The following is a description of a gene set: species: Homo sapiens The chemical reactions and pathways resulting in the breakdown of mRNA, messenger RNA, which is responsible for carrying the coded genetic 'message', transcribed from DNA, to sites of protein assembly at the ribosomes. Human Gene Set: GOBP_MRNA_CATABOLIC_PROCESS, and this is the list of marker genes: MAGOH, FXR2, ARID5A, MIR204, MIR133A1, ATM, CNOT8, HNRNPAB, IGF2BP2, FASTKD1 (FAST kinase domains 1), FASTKD5, MIR103B1, MIR519D, A1CF, MIR373, MIR517A, MIR210, DIS3L2, DAZ4, HNRNPA0, NPM1, ZC3H12D, TENT2, FASTKD2, ZFP36L1, MIR106B, MIR4286, MIR192, MIR495, MIR485 (NCBI Gene Id 574436), MIR497, BTG2, MIR663A, DIS3, CNOT11, MIR365A, MAPKAPK2, TNRC6B, CNOT6, MIR27A, MIR206, ZAR1, EIF4ENIF1, RBM46, NUDT16, MIR543, MIR181D, MIR486-1, MIR106A, CNOT2, RBM33, MIR203A, CELF1, DHX34, ETF1, RBM38, MIR181B1, PDE12, ZC3HAV1, MIR30B, SSB, CNOT3, AXIN2, MIR128-1, NCBP1, MIR20B, MAPK14, MIR655, PIWIL2, TNRC6C, IGF2BP1, MIR212, EXOSC7, PABPC4, LSM5, SENP1, MIR200C, CASC3, UPF3A, PABPN1L, TUT7, MIR562, TIRAP, BOLL, GSPT1, MIR98, NUDT12, ZFP36 (NCBI Gene Id 7538), ZFP36L2, TENT5D, RC3H1, ELAVL4, MIR520C, PNRC2, MEX3D, TENT5C, LSM4, GDNF, LSM2, RIDA, AGO4, MTPAP, MIR885, APEX1, FASTKD3, MIR519A1, PIWIL1, SMG8, TESK1, CNOT1, METTL14 (NCBI Gene Id 57721), MIR665, PYM1, AGO2, NT5C3B, ELAVL1, NBDY, HSPA1B, MIR181A2, CTIF, DHX9, TNRC6A, MIR24-1, TENT5A (terminal nucleotidyltransferase 5A), SKIC2, TENT5B, MIR93, NORAD, UPF1, IKBKE, PKP1, EXOSC5, MIR608, PRR5L, MIR151A, CSDE1, MLH1, MIR423, MIR100, MIR125A, PNRC1, YBX3 (Y-box binding protein 3), MIR142, EDC4, TAF15, TTC5, MIR342, MIR27B, MIR190B, MIR544A, RNPS1, PUM1, MAGOHB, PAN2, GTPBP1, ALKBH5, MIR140, MIR34B, HBS1L, GSPT2, RC3H2, ZC3H14, CIRBP, SKIC3, CACNG7, MIR191, PARN, APOBEC1, MIR337, CSDC2, TRAF2, QKI, NRDE2, ROCK1, EXOSC4, MIR340 (microRNA 340), EXOSC2, NANOS3, MIR149, UPF2, RBM24, PAN3, MIR1-1, NICOL1, AGO1, DXO, MIR199B, POLR2G, SERBP1, SMG9, MIRLET7C, TNKS1BP1, CNOT6L, MIR29B1, NCBP2, KHSRP, NANOS2, MIR137, PRKCD, CNOT4, SMG5 (SMG5 nonsense mediated mRNA decay factor), SUPV3L1, CALCR, PELO, EXOSC3, ZHX2, MIR424, PAIP1, LARP4B, NBAS, MIR329-1, LSM14B, ZC3H12A, MIR320A, ERN1, VIP, TUT1, TENT4A, DAZ3, HSPA1A, YBX1, EXOSC10 (NCBI Gene Id 8619), PABPC1, RBM10, MIR125B1, FBLL1, CNOT10, MIR483, MIR145, MIR96, MIR9-1, MIR146A, MIR193A, RNH1, PATL2, MIR625, MIR501, SMG7, SLC11A1, AGO3, MIR564, EXOSC9, MIR185, PNPT1, MIR26B, EXOSC8, SMG6, TOB1, SCGB1A1, METTL16, AKT1, HNRNPD, HNRNPC, PCBP4, MIR195, DHX36, MIR181C, YTHDF3, XRN1, RBM47, CNOT9, IREB2, XRN2, MIR223, EDC3, DAZ2, CARHSP1, ROCK2, ZCCHC7, SAMD4A, LSM7, SMG1, MIR20A, LSM1, LARP1, RBM8A, GTPBP2, MIR200B, SYNCRIP, TRAF3IP2, TBRG4 (NCBI Gene Id 9238), DCP1B, HNRNPU, VIM, LSM6, MIR326, FTO, PRKCA, UPF3B, GIGYF2, TARDBP, FAM76B, MIRLET7E, EIF4A3, E2F1, TENT4B, SECISBP2, MIR19B1, EIF3E, PATL1 (PAT1 homolog 1, processing body mRNA decay factor), GTSF1, RNASEL, DAZL, DCP1A, THRAP3, FXR1, NOCT, LARP1B, DIS3L, PUM2, FUS, SAMD4B, SLFN14, METTL3, CAPRIN1, MIR211, MIR23A, DCPS (decapping enzyme, scavenger), PLEKHN1, TRAF5, MIR130A, MRTO4, SRSF1, MYD88, MIR302C, MIR19A, YTHDF2, MIR302A, NANOS1, DAZ1, TRIM71, ERI1, MIR517C, MIR135B, PIAS4, MIR18A, MEIOC, DDX5, IGF2BP3, PNLDC1, FASTK, MIR130B, CPEB3, MIR708, NUDT16L1, DND1, MIRLET7B, PKP3, DCP2, YTHDF1, MIR214, SKIC8, SND1, FMR1, EXOSC6, ANGEL2, CNOT7, MIR491, MOV10, TUT4, MIRLET7A1